Given this list of marker genes IMPG1, AKT1, IMPG2, ATOH7, BEST1, PRPH2, here is a description of the gene set: studied in species Homo sapiens Retinal nonattachment Human Gene Set: HP_RETINAL_NONATTACHMENT Failure of attachment of the retina during development.